The following is a description of a gene set: Mouse Gene Set: GOMF_TRANSMEMBRANE_RECEPTOR_PROTEIN_SERINE_THREONINE_KINASE_BINDING studied in species Mus musculus Binding to a receptor that spans a cell membrane and possesses protein serine/threonine kinase activity., and this is the list of marker genes: Smad6, Neo1, Src, Bmp5, Scube3, Elapor2, Acvr1c, Bmp4, Bmp6, Bmp3, Pycard (NCBI Gene Id 66824), Bmp2, Cdh5, Nodal, Smad7, Fkbp1a, Bmp7 (bone morphogenetic protein 7), Inhba, Smurf1, Synj2bp, Cfc1, Magi2, Rspo2, Cripto